The following is a description of a gene set: from publication Chen Y, Wang X (PMID 31504780) Genes predicted to be targets of miRBase v22 microRNA mmu_miR_6929_5p in miRDB v6.0 with MirTarget v4 prediction scores > 80 (high confidence targets). Mouse Gene Set: MIR_6929_5P studied in species Mus musculus, and this is the list of marker genes: Tepsin, Selenom, Plac8l1, Vwa5b2, Mospd3, Cxcr5, Irx6, Spock2, Jade2 (jade family PHD finger 2), Kcnq2, Nav1, Elk1, Drd1, Cyfip2, Zfp275, Rnd1, Cplx2, Cbx5, Spindoc (spindlin interactor and repressor of chromatin binding), Nes, Erf, Agpat1, Susd6, Zmat2, Shisa7, Sox4 (SRY (sex determining region Y)-box 4), Tmem9, Vps25 (vacuolar protein sorting 25), 6430548M08Rik, Arg1, Zmiz1, Wt1, Vsx1, Lrrc72, Calcr, Atp1a3 (NCBI Gene Id 232975), St3gal4, Pomgnt1, Klc2, Klf10, Cfhr1 (NCBI Gene Id 98274), Nbl1, Asxl2, Slc25a10, Cyp2b10, Tm9sf4 (NCBI Gene Id 99237), Hoxc10, Krtap2-20, Ptpn3, Trappc3, Entpd7, Mat2a, Caskin1, Prg4, Smap2, Samd4, Shc1, Ar, Fbln5, Pcp4l1, Erv3, Rac2, Phf21a, Rgs14, Arpc2, Pou2f1, Plxna4, Stk35, Plec, Midn, Dok2, Ralgds, Pde7a, Nrros, Snx19, Ubxn4, Kcne1, Vax1, Mpped1, AU018091 (NCBI Gene Id 245128), Dido1, Sv2c, Pnpla1, Rab35, Eif4ebp3, Gfra2, Mpig6b, Drg2, Thsd7a, Asah2, Baz2a, Vamp2, Sdc3, Leng8, Mtcl2 (microtubule crosslinking factor 2), Srrm4, Snip1, Afap1, Tcf7l2, Iqgap1, Foxk1, S100a16 (S100 calcium binding protein A16), Sgcg, Map3k3, Slc16a14, Sf3b4, Zfp385a, Phf11d, Lhpp, Eif4ebp2, Ess2, Arnt2, Prkce, Cadm3 (cell adhesion molecule 3), Mip, Fkbp10, Agfg2, Cacna2d1, Camkv, Rab3d, Atf6, Ccdc171, Csdc2, Zfp87, Taok3, Syt15, Xkrx, Cts8, Scamp5, Septin11, 6030458C11Rik, Mpp2, Ephb1, Sfmbt1, Lrrc59, Akt2, Pafah1b1, Gstcd, Helb, Slc2a4, Kirrel3, Acsf2 (acyl-CoA synthetase family member 2), Laptm5, 2310022A10Rik, Trmt9b, Shisal1, Rpap2, Nectin1, Bloc1s5, Kcnb1, Elmo1, Camta2, Clstn1, Slc6a18, Cops7a, Ctnnd1, Chd3, Chtf8, Eeig1, Derl1, C2cd4c, Setd1b, Sh2b3, Lzts3, Siglecl2